The following is a description of a gene set: Human Gene Set: GSE27786_LSK_VS_BCELL_DN Each fraction of mouse hematopoietic cells was purified by cell sorting from bone marrow of 8-week-old C57BL/6 mice, and its gene expression was analyzed. studied in species Homo sapiens Genes down-regulated in comparison of LSK versus B cells. from publication Konuma T, Nakamura S, Miyagi S, Negishi M, Chiba T, Oguro H, Yuan J, Mochizuki-Kashio M, Ichikawa H, Miyoshi H, Vidal M, Iwama A (PMID 21540074), and this is the list of marker genes: RNF6, CRKL, CWC15, MFF, MKNK2, FLNA, USPL1 (NCBI Gene Id 10208), SLC38A9, SLC6A5, IFT22, NSMCE4A, TREX2, CCR1, RAD17, MRPL51, PARG, GALNT4, JHY, SP1 (Sp1 transcription factor), WASHC2A, YIPF4, CLCN4, TAF8, ETHE1, CHD8, MFHAS1, SH3TC1 (NCBI Gene Id 54436), SIT1, RLF, HES6, RFLNA, TPGS2, CREB1 (NCBI Gene Id 1385), STX8, OVGP1, RETREG3, WRNIP1, DIPK1A, KXD1, TCOF1, RALGAPB, BRK1, PPP4R3B (NCBI Gene Id 57223), MBD2, MON1B, MPZL2, NEIL1, ATP2A3, ADAMTS6, ARHGEF1 (NCBI Gene Id 9138), ITGA3, MRPS16, USP34, PARP3, IKZF1, WTAP, PANK4, TMA7, SERINC3, COL6A5, CPSF3, VTI1B, LGALS8, PTPRCAP, PTEN, ITGA4, SLC23A1, CWH43, EGFR (NCBI Gene Id 1956), YKT6, RAP1A, LMF2, RAB39A, CDK9 (cyclin dependent kinase 9), MYADM (NCBI Gene Id 91663), CIC, MVP, SIM1, ATXN7, PPP1CC, LRIG2, PSMB10, CRIP3, ARIH2, SERF2, HDAC10, TUSC2, TMEM243, RAC1, SUN2, GNGT2 (NCBI Gene Id 2793), PRKAB2, DPP6, NIP7, CSNK2A1, THEM6, THOC2, MED13, SPATS2L, ICOSLG, SERTAD4, CNR1, AFG2B, PPIA, LSM4, RPL9, SNX12, PSMB4, SQSTM1, FNDC1, CLK3, CYP39A1, CAMK1D (calcium/calmodulin dependent protein kinase ID), SYT3, NR3C1, TRIR, DAD1, DERL2, CAMSAP2, RAP1B (RAP1B, member of RAS oncogene family), UGT2B10, RIPOR2, ACSM2A, NDUFS4, VHL, ANKRD13D, ESYT1, NRBF2, TEX30, EIF4A2, GNAI2, DPT, SNX5, RNF19B, DBH, IL10RB, MALAT1, ARF6, PHIP, TMEM161B, CHIA, HYPK, ACD, ADAM28, SNN, EIF4ENIF1, LY9, ADRA2B, RNF185, MRPL52 (mitochondrial ribosomal protein L52), TET2, KDM1B, PSMD14 (proteasome 26S subunit, non-ATPase 14), VIM, MON2, WRAP73, SNF8, KCNMB4, AKAP8 (NCBI Gene Id 10270), ANKRD12, FGF4, POLDIP3, STAC, CRISPLD2, TRIM36, ZNF707, CIAO1, ARHGDIB, CHML, NLK, GRB7, RPL31, TUBB2B, RFX5, RGS11, RPS6KB2, STARD5, NECAP2, POLR3F, NEDD8, GRIPAP1, OSBPL11, TFAM, FLRT1, ESCO1, SRA1, SBNO1, EMP3, ZFAND3, CTCF, ATG3, MANF, PRR5, PRR14, POMT2, DOCK2, GIMAP6, CHRNA9 (NCBI Gene Id 55584), HIGD2A